Given this list of marker genes SHANK2, PCDH9, ITGA4, USH2A, MAP2, PTK2B, CYTH2, ZPR1, GDPD5, TRAK1, KCNC2, DRD2, ACTG1, ROR1, FRMD7, SLC8A2, SYAP1, PACSIN1, AMFR, ACAP3, TBC1D24, PTBP2, COPG2, GHRH, RAB5A, PAFAH1B1, ARHGAP4, UNC13B, EXOC3, MICAL1, NGEF, PINK1, CDK5R2, DCTN2, ELFN1, LRRK2, BRSK2, SHTN1, UNC5C, SSH1, ELAVL4, SYNJ1 (synaptojanin 1), SNAP25, KIF5C, MAPT, PTCH1, CD2AP, ITGA3, CIB1, DSCAM, FSCN3, UNC13C, KCNC4, NIN, RASGRF1, OTX2, KIF20B, CFL1, SNCB, MAP3K12, AP1S1, CNR1, FMR1, PTPRN, LRRTM1, SLC4A10, CRMP1, GAP43, FLRT3 (NCBI Gene Id 23767), TSPOAP1, CPEB4, FLNA, PENK, CTTN, USP9X, CALM3, TWF2, NTRK2, ABI1, RAB3A, EXOC4, SETX, NDRG2, KCNC3, STMN3, CALB1, DOCK7, HSP90AA1, SLC4A8, CALB2, OXT, SLC8A1, MYH10, PCDHGB1, CDH8, RTN4R, TRPC5, NPY, KCNQ5, SCN9A, PRKN, PRKCB, WDR47, DVL1, CBARP, LAMP5, GRIK2, CRHBP, TPRG1L, TSHZ3, TPBG (trophoblast glycoprotein), NEFL, SLC2A13, HAP1, MAPK8IP3, MYO9A (NCBI Gene Id 80251), CAD, EXOC7 (exocyst complex component 7), APP, DBN1, TENM2, KIF21B, KCNA6, SCGN, KCNC1, ABL1, SRSF10, STMN2, PRRT2, ITGA2, CDKL5, CABP4, IGF2BP1, SLC6A3, SLC17A8, TANC1, SCN11A, WHRN, PNOC, PRSS12, STX3, L1CAM, ELK1, APBB2, UCN, INPP5J, NPFF, ATP6V0D1, C9orf72, APBB1, NMU, FEZ1, LRIG2 (leucine rich repeats and immunoglobulin like domains 2), CPLX3, EXOC6, DPYSL3, NRXN1, BASP1, COBL, SEPTIN6, PRKCG, FKBP4, ATCAY, ADGRL1, SLC32A1, TRAK2, CALM1 (NCBI Gene Id 801), CBL, IGHMBP2, ALS2, LMTK2, OPHN1, SLC18A2, BOC, PALLD, CPLX1, NGFR, SIRT2, AAK1, DISC1, RUFY3, PDYN, UNC13A, TULP1, AP3D1, MAPK8IP1, TAOK2 (TAO kinase 2), RAC3, UCN3, PRNP, NTSR1, GRIN1, SYP, ENO2, CHRM1, TOR1A, STMN4, NEO1, TUBB3, ZNF804A, PPP1R9B, HCN1, MAP1B, GPM6A, AUTS2, TRPV4, NRSN1, HSP90AB1, SNCG, SLC18A3, EPHA4, SIGMAR1, TRPV2, MYO5A, CASR, PTPRS, CPLX4, NECTIN1, CCDC120, CALM2, COPA, CDK5, FSCN1, GNRH1, ADCY10, PTPRO (NCBI Gene Id 5800), SLC8A3, FGF13 (fibroblast growth factor 13), GIT1, ANG, CLCN3, KIF21A, GAD1 (NCBI Gene Id 50977), CNGB1, OPRK1, KATNB1, ABITRAM, OPRD1, TNN, PREX1, KCNK2, MYH14, CSNK1E, TIAM2, PSEN1, OLFM1, KLC1, ADRA2A, GRIK3, CRHR2, BRSK1, ERC2 (ELKS/RAB6-interacting/CAST family member 2), CTSZ, ADORA1 (NCBI Gene Id 134), SNCA, GPER1, IQGAP1, SLC1A1, CLASP2, ZFYVE27, NTS, DTNBP1, GOT1, CXADR, ACTB, FKBP15 (NCBI Gene Id 23307), THY1, DNM2, CDK5R1, SLC18A1 (solute carrier family 18 member A1), KCNA2, EXOC8, ARPC3 (NCBI Gene Id 10094), EPS8, CRTAC1, NOS1, BIN1, KCNA1, GPRIN1, CPLX2, here is a description of the gene set: That part of an axon close to and including the growth cone or the axon terminus. species: Homo sapiens Human Gene Set: GOCC_DISTAL_AXON